The following is a description of a gene set: Downregulation of SMAD2/3:SMAD4 transcriptional activity species: Mus musculus Mouse Gene Set: REACTOME_DOWNREGULATION_OF_SMAD2_3_SMAD4_TRANSCRIPTIONAL_ACTIVITY, and this is the list of marker genes: Ube2d3, Mapk1, Ubb, Parp1, Rps27a, Tgif2, Uba52rt, Ski, Usp9x, Ube2d1, Mapk3, Smurf2, Uba52, Ncor2, Smad2, Ubc, Skil, Hdac1 (NCBI Gene Id 630524, histone deacetylase 1), Ppm1a, Smad3, Nedd4l, Smad4, Atp1b4, Tgif1